The following is a description of a gene set: A non-motile cilium where the axoneme has a ring of nine outer microtubule doublets but no central microtubules (and is therefore called a 9+0 axoneme). Mouse Gene Set: GOCC_9PLUS0_NON_MOTILE_CILIUM species: Mus musculus, and this is the list of marker genes: Pkhd1, Vcan, Prom1, Tulp3, Rapgef4, Impg1, Gnat1, Atp1a4, Pde6a, Enkd1, Plekhb1, Tbcc, Rd3, Kifap3, Arl3, Stx3, Prcd, Pdc, Ttc8, Iqcb1 (NCBI Gene Id 328669), Smo, Gucy2e, Alpk1, Opn1sw, Rpgrip1l, Ift57 (NCBI Gene Id 73916), Rp1, Cdhr1 (cadherin-related family member 1), Rom1 (rod outer segment membrane protein 1), Ush1g, Iftap, Ptgs1, Adgrv1, Ift122, Cetn2, Ift88, Wdr19, Crb1, Sag, Opn3 (opsin 3), Mak, Cep250, Cep290, Myo3b, Phyh, Fam161a, Pde6h, D630045J12Rik, Myo7a (NCBI Gene Id 17921), Nxnl1, Ccdc66, Gnat2, Tmem237, Prph, Hnf1a, Pde6g, Rpgr, Sptbn5, Arr3, Pex6, Cfap410, Nphp1, Kif3a, Cnga3, Abca4, Cacna1f, Bbs4, Guca1b, Bbs7, Ttll5, Ttll4, Ocrl, Map1a, Slc24a4, Ttll6, Cerkl, Dynll2, Ahi1, Rpgrip1, Pcdhb22, Tulp1, Topors, Cetn1, Myo5a, Pip4k2a, Gnb1, Cib2, Grk1, Opn5 (NCBI Gene Id 353344), Phlpp2, Bsg, Tsga10ip, Prph2, Myrip, Ift140, Rdh11, Kif17, Nup42, Spata7, Gngt1, Ush1c, Ptprk, Cetn3, Whrn, Ift20, Lyar, Shank2, C130074G19Rik (NCBI Gene Id 226777), Prkca, Lca5, Nphp4, Pcare, Ift80, Cngb3, Rab27a, Rcvrn, Mertk, Sdccag8, Pcdh15, Septin2, Cngb1, Inha, Ush2a, Guca1a, Pcdhb16, Magi2, Gucy2f, Cnga1, Rho, Pde6b, Ttll7, Ift52, Opn1mw, Poc5, Map1b, Rp1l1 (retinitis pigmentosa 1 homolog like 1), Cfap96